Given this list of marker genes St3gal6, Hjurp, Tfap2b, Arl4a, Parp11, Kctd6, P4hb, Mlf1, Mpzl2, Vmp1, Arrdc3, Ring1, Pitpnb, Glcci1, Abcb1b, Zc3h13, Naa30, Bdnf, Nkrf, Plxna2 (plexin A2), Zfyve27, Ptx3, Sptlc2, Smc1a, Septin7, Pkn2, Gpm6b, Tmem33, Ambn, Jhy, Ankrd17, Btg3, Rap1a, Ythdf2 (NCBI Gene Id 352969), AI593442, Grsf1, Kif15, Top1, Fam184a, S100a14, Zbtb8a, Cthrc1, Sfrp4, Thbd, Stx17, Casp8ap2, Syde2, C2cd3, Jag1, Ccn1, Hes1, Gabarapl2, Dip2c, Vav3, Socs5, Ireb2, Aurkaip1, Fam168a, here is a description of the gene set: species: Mus musculus Genes predicted to be targets of miRBase v22 microRNA mmu_miR_16_2_3p in miRDB v6.0 with MirTarget v4 prediction scores > 80 (high confidence targets). Mouse Gene Set: MIR_16_2_3P from publication Chen Y, Wang X (PMID 31504780)